Given this list of marker genes CAMK1D (calcium/calmodulin dependent protein kinase ID), SLAMF8, NCF1B, NCF1, LIPA, SLC11A1, RAC1, NOX1, CD24, CYBB, IGHA2, NOXO1, IGHA1, CYBC1, BCR, RPS19, LBP, CYBA, S100A9, CD55, PIK3CD, CLEC7A, INS, GRN, INSR, TREM2, NCF4, SELENOK, NCF1C, HCK, DUSP10, MPO, NOXA1 (NADPH oxidase activator 1), JCHAIN, PIK3CG, RAC2 (Rac family small GTPase 2), CD52, NCF2, PRDX2, RAC3, here is a description of the gene set: species: Homo sapiens Human Gene Set: GOBP_RESPIRATORY_BURST A phase of elevated metabolic activity, during which oxygen consumption increases; this leads to the production, by an NADH dependent system, of hydrogen peroxide (H2O2), superoxide anions and hydroxyl radicals.